Given this list of marker genes PRSS35, FAM210B, HOXA5, FZD6, CD200, LYZ, DSP, MAP3K7CL, RGS5, FOXF1, TCEAL1, BLOC1S3, DAPK1, PGPEP1, ADAMTS5, C1QB, PDE5A, ABLIM1, IL2RG, SLFN12, AGA, ESD, DCAF12L1, AIF1L, SAT1, LPCAT2, SUSD2, EPCIP, CMBL, ALDH1A1, CCDC68, CTSC, CERS4, SPON2, SYTL2, MEST, PIERCE1, ZNF429, C4orf3, PSME2, EMCN, SSBP2, SFN, FBXL7, RPLP1, FJX1, TNNC1, CCL25, C1QTNF12, TNNT2, HMCN1, BMP4, LAPTM5, GATM, SPSB1, PALMD, GDF15, FAS, LAMA5 (NCBI Gene Id 3911), HOXC6, JPT2, CCL17, SNCG, C3AR1, ADAMTS10, GADD45A, PLOD2, PCGF5, KIF21B, KLHL30, DUSP6, GPR148 (NCBI Gene Id 344561), MCEE, EPHA4, SERPING1, GPX3, PLEKHH2, PPP1R14A, FAM177A1, DDAH2, C1QC, SLAMF9, CXCL12, ABHD1, FOXC1, KCNMB1, OR6C70, IFI44, PITX2, NUPR1, RARB, NRK, IRGM, ENG, DHRS3, C1QA, LDB2, NOTCH3, ITGA3, EBPL, ALX1, SLC25A17, OLFML2B, GALNT11 (polypeptide N-acetylgalactosaminyltransferase 11), COL11A1, IGF2R, PDGFB (platelet derived growth factor subunit B), IGFBP2, DGKK, MIR4435-2HG, NFKBIE, CCNG2, RABL2B, EPHA7, APOE, PTP4A3, CD52, ALDH1A3, IER3IP1, TIMM8B, FXYD6, C19orf33, RFLNB, HIPK2, CTSS, MPEG1, MMP2, FIBIN, DNER, SLC16A4, ITPRIPL2, SULT4A1, PAPPA2, HOXA6, MYO7A, TGM2, VNN1 (NCBI Gene Id 8876), MOGAT2, KRTAP5-2, TMTC1, MYOM1, IGF1, SFI1, CYBB, ALKAL1, NTN4, CDH10, SORT1, DMPK, MYL12B, SCUBE3, POPDC2, TMEM223, ATP10D, ANKRD44, STOM, RENBP, TMEM88, HOXB6 (NCBI Gene Id 3216), SYCP3, HOXB9 (NCBI Gene Id 3219), DUX4L4, GDPD5, FOXD1, CDKL3, ADGRF5, CTSH, PLEKHA2, MYH11, SLC7A7, KLHL24, NES, STYXL2, ANKRD1, TXNIP, here is a description of the gene set: Genes up-regulated in MEF cells (embryonic fibroblast) with ELAVL1 knocked out. studied in species Mus musculus from publication Katsanou V, Milatos S, Yiakouvaki A, Sgantzis N, Kotsoni A, Alexiou M, Harokopos V, Aidinis V, Hemberger M, Kontoyiannis DL (PMID 19307312) HuR is an RNA-binding protein implicated in a diverse array of pathophysiological processes due to its effects on the posttranscriptional regulation of AU- and U-rich mRNAs. Here we reveal HuR's requirement in embryonic development through its genetic ablation. Obligatory HuR-null embryos exhibited a stage retardation phenotype and failed to survive beyond midgestation. By means of conditional transgenesis, we restricted HuR's mutation in either embryonic or endothelial compartments to demonstrate that embryonic lethality is consequent to defects in extraembryonic placenta. HuR's absence impaired the invagination of allantoic capillaries into the chorionic trophoblast layer and the differentiation of syncytiotrophoblast cells that control the morphogenesis and vascularization of the placental labyrinth and fetal support. HuR-null embryos rescued from these placental defects proceeded to subsequent developmental stages but displayed defects in skeletal ossification, fusions in limb elements, and asplenia. By coupling gene expression measurements, data meta-analysis, and HuR-RNA association assays, we identified transcription and growth factor mRNAs controlled by HuR, primarily at the posttranscriptional level, to guide morphogenesis, specification, and patterning. Collectively, our data demonstrate the dominant role of HuR in organizing gene expression programs guiding placental labyrinth morphogenesis, skeletal specification patterns, and splenic ontogeny. Human Gene Set: KATSANOU_ELAVL1_TARGETS_UP